Given this list of marker genes SAMSN1, NEXMIF, CD274, SLC8A1, VSIG4, ADGRE2, LINC03070, RAB20, PRAM1, SLC39A13-AS1, ENPP2 (ectonucleotide pyrophosphatase/phosphodiesterase 2), ADGRE1, EYA2, ANKRD24, LY96, SIGLEC1, ITGAX, RASSF4, KCNMA1, GPR137B, NCF2, MS4A7, NAIPP2, CARD14, OSCAR, MRO, KCNAB1, LILRB3, WWP1, MS4A4E, CD86, ADGRE4P, HCK, RN7SL138P, LGMN, FLVCR2, LRRK1, DMXL2, OSM, GHRL, SIGLEC7, ENSG00000254288 (novel transcript), AGR2, ZNF710, DSCAM, IGSF6, TMEM63C, FMN1 (formin 1), CD163L1, NABP1, IL15, IL1B, ADAP2, ITGAD (integrin subunit alpha D), NRIR, RGL3, SIRPB1, HRH1, NOD2, MERTK, PID1, MS4A4A (membrane spanning 4-domains A4A), CD300LF, MKNK1, CSF2RA, FCGR1A, LILRB5, NLRP3, LINC01645, CABP4, MNDA, LILRB1, IL1RN, ENSG00000253557, RAB39A (NCBI Gene Id 54734), CLEC7A, RASGEF1C, S100Z, FABP5, FCN1, SIGLEC16, LILRB4, GGTA1, IL1R2, IDO1, MEGF11, TIMD4, PDCD1LG2, CLNK, NAIP, SIGLEC5, LYZ, CD163, BATF3, SMIM35, ZNF415P1, SPIC, LILRB2, LINC00996, MS4A6A, LILRA5, TGFA, CD200R1, PTPRE, IGSF21, THEMIS2, CDS1, NCKAP5, TRIM36, PFDN1P1, DSCAM-IT1, EPB41L3, IL10, FAM20A, ALMS1P1, CMKLR1, IL10RA, C3AR1, RUFY4, CHN2, TRPV4, FCAR, EBI3, KCNK13, PPARG, ENSG00000227531, SIRPB2, HK3, MCOLN1, CLEC9A, CCDC170, IFI44L, CXCL10, RGS1, here is a description of the gene set: Marker genes curated from the annotated cluster as represented in the Descartes Human Gene Expression During Development database. Human Gene Set: DESCARTES_FETAL_SPLEEN_MYELOID_CELLS from publication Cao J, O'Day DR, Pliner HA, Kingsley PD, Deng M, Daza RM, Zager MA, Aldinger KA, Blecher-Gonen R, Zhang F, Spielmann M, Palis J, Doherty D, Steemers FJ, Glass IA, Trapnell C, Shendure J (PMID 33184181) The gene expression program underlying the specification of human cell types is of fundamental interest. The study authors generated human cell atlases of gene expression and chromatin accessibility in fetal tissues. For gene expression, the study authors applied three-level combinatorial indexing to >110 samples representing 15 organs, ultimately profiling ~4 million single cells. The study authors leveraged the literature and other atlases to identify and annotate hundreds of cell types and subtypes, both within and across tissues. Our analyses focused on organ-specific specializations of broadly distributed cell types (such as blood, endothelial, and epithelial), sites of fetal erythropoiesis (which notably included the adrenal gland), and integration with mouse developmental atlases (such as conserved specification of blood cells). These data represent a rich resource for the exploration of in vivo human gene expression in diverse tissues and cell types. species: Homo sapiens